Given this list of marker genes INPP5K, MIR195, PRKAG3, ENPP1, GSK3A, MIR1271, GSK3B, SELENOS, MIR15B, GRB10, PASK, here is a description of the gene set: studied in species Homo sapiens Human Gene Set: GOBP_NEGATIVE_REGULATION_OF_GLYCOGEN_BIOSYNTHETIC_PROCESS Any process that stops, prevents, or reduces the frequency, rate or extent of the chemical reactions and pathways resulting in the formation of glycogen.